Given this list of marker genes CPLX1, NSD2, NPR3, COG4, SALL1, FGFRL1, CTBP1, LETM1, PCNT, RPS6KA3, here is a description of the gene set: Human Gene Set: HP_METACARPAL_PSEUDOEPIPHYSIS A pseudoepiphysis is a secondary ossification center distinct from the normal epiphysis. The normal metacarpal epiphyses are located at the distal ends of the metacarpal bones. Accessory epiphyses (which are also known as pseudoepiphyses) can also occasionally be observed at the proximal ends of the metacarpals, usually involving the 2nd metacarpal bone. studied in species Homo sapiens Metacarpal pseudoepiphysis